The following is a description of a gene set: Human Gene Set: GSE33292_DN3_THYMOCYTE_VS_TCF1_KO_TCELL_LYMPHOMA_UP Genes up-regulated in wildtype DN3 thymocytes versus T cell lymphoma cells from TCF7 knockout. TCF-1 is an HMG family transcription factor which is known to be critical for T cell development. We discovered that it has a unique role in suppressing malignant transformation of developing thymocytes at early stages. We identified ID2 and LEF-1 as key TCF-1 target genens in tumor suppression. We used microarrays to detect gene expression changes in WT and TCF-1 deficient DN3 thymocytes as well as T cell lymphoma cells developed in TCF-1 KO mice. from publication Yu S, Zhou X, Steinke FC, Liu C, Chen SC, Zagorodna O, Jing X, Yokota Y, Meyerholz DK, Mullighan CG, Knudson CM, Zhao DM, Xue HH (PMID 23103132) species: Homo sapiens, and this is the list of marker genes: AQP8, HSPA4L, ATIC (5-aminoimidazole-4-carboxamide ribonucleotide formyltransferase/IMP cyclohydrolase), PRMT1, MTHFD1, TMED3, CD52, ARHGAP25, CYP1B1, CYBB, IMP4, CD1C (CD1c molecule), SORL1, TICAM1, IL27RA, CD48, H2BC5, GTF2H5, SLC6A12, SIGLEC6, MT2A, PTPN21, BNIP3, TRAF3IP2, GCNT1, KLF9, MRPL23, MATK, TMC6, NTHL1, ABCD4, TFRC, GCLC, CREG1, DNPEP, ABCE1, RMND5B, STX3, DUSP2, CELSR1, PTPN22, TXN, IQSEC2, FURIN, SPINT1, XK, TRAP1, SH3BP5, PRNP, MS4A1, LCK, MRPS12, ABCF2, CXCL11, H2AC6, GABBR1, PKIG, TRIB2, GPR65, RUNX3, CHI3L2, EVI2A, HSPB1, SORD, LTB, CD44, MT1A, RABEPK, BHLHE40, NDUFAF1, CR2, ARMCX2 (armadillo repeat containing X-linked 2), CCR6 (C-C motif chemokine receptor 6), LIPA, DAZL, TMEM147, SNAP23, SRM, MRPS18B, POLD4, RNH1, JRK, SERPINI1, TBC1D9, HLA-DQB1, APRT, RNASE6, SPARC, ITGB2 (NCBI Gene Id 3689), PPP1R16B, PCCB (NCBI Gene Id 5096), FAM216A, CD55, SMAGP, ADAM8, CYP27A1, TIMM44, RGS9, KAT2A, GCFC2, ALOX5AP, TRAT1, TRAF3IP3, MEST, C1QBP, CA2, CCL4, TELO2, MAP4K4 (NCBI Gene Id 9448), GLS2, GGA2, MRPL12, EXOSC7, UTP25, IL4R (interleukin 4 receptor), CCR3, ABCA3, PFKM, LY86, GALE, UMOD, SELL, RPP40, MAP3K8, TOX, UCHL3, PNLIP, SLC25A13, EEF1E1, AHNAK, NAAA, LGALS2, BIRC3, PDHA1, HLA-DOB (NCBI Gene Id 3112), NTNG1, TRAF5, IMPDH1, TSFM (Ts translation elongation factor, mitochondrial), UROS, ABLIM1, ICAM2, ST6GAL1, PWP2, TRHR, LIPT1, LY96, LPXN, TRAPPC6A, RALGAPA1, SUOX, CD96, NDUFS5, PEPD, PTPRK, GALC, SLC39A14, STAT6, UBXN8, H2BC21, CACNG3, SRRD, LSM7, LY75, TCEAL1, MMP10, AHCY, OAT (ornithine aminotransferase), IGHD, WDR18, FCMR, P2RY14, CCL17, ALDH1A1, WDR43, HSPBP1, TBL1X, FLAD1, ANXA4, MTSS1, MPHOSPH10, IFI30, PLEK, NCLN, GNL2, HHEX, ACE, CDC34, CLCN7, KNOP1, HMBS, HDDC2, ITPR1, PNO1, SWAP70, TMSB4Y, SEZ6L, CD1D, SLC7A7